The following is a description of a gene set: Genes down-regulated in comparison of monocytes treated with anti-TREM1 and 5000 ng/ml LPS (TLR4 agonist) versus untreated monocytes. from publication Dower K, Ellis DK, Saraf K, Jelinsky SA, Lin LL (PMID 18292579) species: Homo sapiens TREM-1 is an orphan immunoreceptor expressed on monocytes, macrophages, and neutrophils. TREM-1 associates with and signals via the adapter protein DAP12/TYROBP, which contains an immunoreceptor tyrosine-based activation motif (ITAM). TREM-1 activation by receptor cross-linking is pro-inflammatory, and can amplify cellular responses to Toll-like receptor (TLR) ligands such as bacterial lipopolysaccharide (LPS). To investigate the cellular consequences of TREM-1 activation, we have characterized global gene expression changes in human monocytes in response to TREM-1 cross-linking in comparison to and combined with LPS. Both TREM-1 activation and LPS up-regulate chemokines, cytokines, matrix metalloproteases, and PTGS/COX2, consistent with a core inflammatory response. However, other immunomodulatory factors are selectively induced, including SPP1 and CSF1 (i.e., M-CSF) by TREM-1 activation and IL-23 and CSF3 (i.e., G-CSF) by LPS. Additionally, cross-talk between TREM-1 activation and LPS occurs on multiple levels. While synergy in GM-CSF protein production is reflected in commensurate mRNA abundance, comparable synergy in IL-1b protein production is not. TREM-1 activation also attenuates the induction of some LPS target genes, including those that encode IL-12 cytokine family subunits. Whereas positive TREM-1 outputs are abolished by the PI3K inhibitor wortmannin, this attenuation is largely PI3K-independent. These experiments provide a detailed analysis of the cellular consequences of TREM-1 activation, and highlight some of the complexity in signal integration between ITAM- and TLR-mediated signaling. Human Gene Set: GSE9988_ANTI_TREM1_AND_LPS_VS_VEHICLE_TREATED_MONOCYTES_DN, and this is the list of marker genes: RHOG (NCBI Gene Id 391), ENC1, RASSF2, COTL1, MRFAP1, ARL6IP5, CASP8, CAP1, PIK3R5, BMF, ATF5, ZNF780A, STX6, IRF5, DDX17, SLX4, RGS19, SLC43A2, ENG, SRSF9, SUN2, NCOA4, TACC1, CSK, TMED9, ZNF710, DCAF12, KDM4A, IKBKE, TGFBI, ANKRD13D, BUD13, YWHAB, FUCA1, SETD1B, RAB31, PRR13, KLHDC10 (NCBI Gene Id 23008), GDI2, RAC1, MAST3, HECA, PCBP1, ARL3, CXCL16, CXCR4, TFEB, TNFRSF1A, CDC34, USP19, BCDIN3D, DOK2, OTULINL, THAP11, CTNND1, ARRB1, ARHGAP30, PATZ1, ZNF436, MOB3A (NCBI Gene Id 126308), FAM89B, RPS6KA1, ENO1, POU2F1, NPC2, PAGR1, ARHGAP22, DIS3L, MAP7D1, RAB5IF, RUNX3 (RUNX family transcription factor 3), DNAL4, MPEG1, TLR1, LRG1, TCF20, PIK3CD (phosphatidylinositol-4,5-bisphosphate 3-kinase catalytic subunit delta), FRAT1, RPL27, IL27RA, NAGS, CTSH, TNRC6A, RASSF5, OAZ1, KCTD2, STK24 (NCBI Gene Id 8428), CMTM3, PTTG1IP, TNFRSF10D, KLHDC3, PPP1R18, DUSP7, CBL, WRAP73, TRIM8 (NCBI Gene Id 81603), NECTIN2, CCM2, NCKAP5L, ATXN7L3 (ataxin 7 like 3), NELFA, ARPC1B (actin related protein 2/3 complex subunit 1B), GIT2, TNFAIP8L1, CYTIP (NCBI Gene Id 9595), LFNG, CAPZA1, NFIC, NT5DC2, PHF23, YWHAG (tyrosine 3-monooxygenase/tryptophan 5-monooxygenase activation protein gamma), KLF13, PPP1R9B, SDHA, SUMO2, PURA, CCR2, GABARAP, CSF1R, SLC16A3, ACP5, ELOVL1, FAM78A, MYO1F, CD14, ABI3, EMP3, SASH3, TGIF2, DR1, PSAP (NCBI Gene Id 83009), NLRC4, CALM2, GRN, WDR82, HCK, NRDE2, FPR3, IFI30, VPS35, ATG9A, CX3CR1, STK11, PLIN3, SH2D3C, MLXIP, MR1, GNB2, TARS2 (NCBI Gene Id 80222), EXTL3 (NCBI Gene Id 2137), ZC3H10, CALHM2, MARCKSL1, TUSC2, MRTFB, LGALS1, TNRC18, PLXNB2, BCL3, CORO1A, CASP10, APOBR, GNAI2, TWF2, PLEKHO2, IL10RA, ARRDC2, MIGA2, PRELID1, RAB11FIP4, PTP4A2, DAGLB (diacylglycerol lipase beta), BCL9L, LAPTM5, EVI2A, CLIC1, CENPB, GAL3ST4, RAP2B, GAPT (NCBI Gene Id 202309), MAP3K3, PPP1CA, POLR2B, WBP1L, TNFAIP8L2, DSTYK, NLRP12 (NLR family pyrin domain containing 12), EMSY, ZFP36L2, BAZ1B, ARHGAP27, KIF3B, MAPK1, SMARCAL1, CTDSP1, GIMAP8, DYNLL1